Given this list of marker genes Hnrnpu, Cenpe, Ttc28, Map10, Map9, Eml1, Cttn, Numa1, Aurkb, Rcc2, Kif18b, Or2a7, Prc1, Kif20b, Kif18a, here is a description of the gene set: Mouse Gene Set: GOCC_MITOTIC_SPINDLE_MIDZONE The area in the center of the anaphase spindle consisting of microtubules, microtubule bundling factors and kinesin motors where the spindle microtubules from opposite poles overlap in an antiparallel manner. studied in species Mus musculus